Given this list of marker genes Btc, Pik3r1, Nrg1, Pik3ca, Nrg3, Ereg, Erbb4, Hbegf, here is a description of the gene set: studied in species Mus musculus PI3K events in ERBB4 signaling Mouse Gene Set: REACTOME_PI3K_EVENTS_IN_ERBB4_SIGNALING